Given this list of marker genes Fmnl1, Pclo, Cyfip1, Htt, Rhoq, Actg1, Evl, Vasp, Enah (NCBI Gene Id 98642), Dbn1, Cttn, Diaph1, here is a description of the gene set: Mouse Gene Set: GOMF_PROFILIN_BINDING species: Mus musculus Binding to profilin, an actin-binding protein that forms a complex with G-actin and prevents it from polymerizing to form F-actin.